Given this list of marker genes Ubb, Psmd13, Psma4, Cd209a, Psmc1, Psmd12, Calm1, Pak3, Rps27a, Relb, Psma7, Psmc3, Cul1, Psma3, Psmd7, Casp8, Pycard, Nfkb2, Rps6ka5, Psmb5, Nfkb1, Psmc4, Psma5, Psmd1, Ppp3r1, Psma1 (proteasome subunit alpha 1), Psmb4, Tab2, Psma6, Malt1, Clec4d, Psmd6, Psmb7, Tab1, Psmc2, Map3k14, Psmc5, Ube2v1, Pdpk1, Psma2, Cdc34, Ube2d1, Ep300, Nfkbia, Card9, Tab3, Rela, Clec4n (NCBI Gene Id 56620), Syk, Plcg2, Ikbkb, Prkacb, Icam2, Psmb6, Ube2n, Prkaca, Fyn, Psmc6, Hras, here is a description of the gene set: part of: Innate Immune System This event has been computationally inferred from an event that has been demonstrated in another species.<p>The inference is based on the homology mapping from PANTHER. Briefly, reactions for which all involved PhysicalEntities (in input, output and catalyst) have a mapped orthologue/paralogue (for complexes at least 75% of components must have a mapping) are inferred to the other species. electronically inferred by orthology from the curated human pathway studied in species Mus musculus Reactome Pathway: C-type lectin receptors (CLRs)